Given this list of marker genes PKHD1, BBS5 (Bardet-Biedl syndrome 5), CLDN1, IFT122, PLIN1, GBA1, ANKS6, MET, TRIM32, BBS1, DYNC2H1, WDPCP, MARS1, DYNC2I1, RPGRIP1, TMEM107, POU2AF1, STN1, LYN, ACADVL, MPV17 (mitochondrial inner membrane protein MPV17), PEX1, NEK8, BBIP1, NOTCH1, UNC45A, SPIB, CEP164, NPHP1, TERT, DLL4, SCYL1, LIPA (lipase A, lysosomal acid type), CEP290, BCS1L, AGL, IFT172, ARL6, TXNDC15, RPGRIP1L, AP1S1, TCF4, ALG9, USP53, SKIC2, PNPLA6, HJV, IARS1, TMEM237, MMEL1 (membrane metalloendopeptidase like 1), RNU7-1, MPI, RBPJ, SEMA4D, ABCB4, GPD1 (NCBI Gene Id 2819), SCAPER, TMEM216, GPR35 (NCBI Gene Id 2859), CC2D2A, EOGT, RINT1, SLC51B, TCTN1, UBR1, MKKS (MKKS centrosomal shuttling protein), B9D2, ASAH1, SCLT1 (sodium channel and clathrin linker 1), PHKB, BBS4, WDR19, MTTP, TNPO3, TTC8, DZIP1L, PYGL, CFAP418, CTNNB1, PMM2, CEP19, BBS9, WDR35, CP, TNFSF15, IL12RB1, INPP5E, ALMS1, MED12, INVS, MKS1 (MKS transition zone complex subunit 1), KIF3B (NCBI Gene Id 9371), DPM1 (dolichyl-phosphate mannosyltransferase subunit 1, catalytic), CCDC28B, INSR, IQCB1, B9D1, KIF12, NOP10, ARHGAP31, ATP6AP1, HBB, NPHP4, TMEM67, TCTN3, LZTFL1, CYP7B1, TALDO1, IFT74, TMEM199, SLC25A13, SC5D, IRF5 (interferon regulatory factor 5), DYNC2I2, ASL, CSPP1, DGUOK, NGLY1, MST1, STX5, IFT56, BBS7, GLIS3, NEK1, PHKG2, BBS10 (Bardet-Biedl syndrome 10), PTRH2, NPHP3, IFT140, SDCCAG8, SLC51A, TMEM231, IL12A, ABCD3, PHKA2, DNASE2, DCDC2, IFT80, TRAF3IP1, PRIM1, TCTN2, OFD1, DOCK6, FADD, TULP3, BBS2, IFT27, BBS12, RBCK1 (NCBI Gene Id 10616), HAMP, NHP2, SKIC3, here is a description of the gene set: The presence of excessive fibrous connective tissue in the liver. Fibrosis is a reparative or reactive process. Human Gene Set: HP_HEPATIC_FIBROSIS species: Homo sapiens Hepatic fibrosis